Given this list of marker genes NFE2L2, MAFK, EP300, MYC, CREBBP, NOTCH1, NFKB1, RELA, here is a description of the gene set: Reactome Pathway: Regulation of NFE2L2 gene expression studied in species Homo sapiens part of: Nuclear events mediated by NFE2L2 Sub-pathway represents a collection of events involved in the expression of the NFE2L2 gene. The NFE2L2 gene is transcriptionally regulated by multiple transcription factors like Myc, NFKB, NFE2L2 itself and many more. This diverse regulation of NFE2L2 connects its regulation with other signalling pathways